Given this list of marker genes GALT, here is a description of the gene set: species: Homo sapiens Galactose-1-phosphate uridylyltransferase (GALT) is one of the enzymes involved in galactose metabolism in the Leloir pathway. GALT catalyses the transfer of uridine monophosphate (UMP) from UDP-glucose (UDP-Glc) to galactose-1-phosphate (Gal1P) to form UDP-galactose (UDP-Gal) and glucose 1-phosphate. Defects in GALT can cause Galactosemia (GALCT; MIM:230400), an autosomal recessive disorder of galactose metabolism presenting in neonatals that causes jaundice, cataracts and mental retardation. part of: Diseases associated with glycosylation precursor biosynthesis Reactome Pathway: Defective GALT can cause GALCT